The following is a description of a gene set: Mouse Gene Set: GOBP_REGULATION_OF_ESTABLISHMENT_OF_PROTEIN_LOCALIZATION_TO_CHROMOSOME Any process that modulates the frequency, rate or extent of the directed movement of a protein to a specific location on a chromosome. studied in species Mus musculus, and this is the list of marker genes: Cct8, Tcp1, Cct3, Wrap53 (WD repeat containing, antisense to Trp53), Cct2, Acd, Spidr, Cct5, Cct4, Cct7, Dkc1, Terf1, Cct6a